The following is a description of a gene set: Human Gene Set: GOBP_PROTEIN_N_LINKED_GLYCOSYLATION_VIA_ASPARAGINE studied in species Homo sapiens The glycosylation of protein via the N4 atom of peptidyl-asparagine forming N4-glycosyl-L-asparagine; the most common form is N-acetylglucosaminyl asparagine; N-acetylgalactosaminyl asparagine and N4 glucosyl asparagine also occur. This modification typically occurs in extracellular peptides with an N-X-(ST) motif. Partial modification has been observed to occur with cysteine, rather than serine or threonine, in the third position; secondary structure features are important, and proline in the second or fourth positions inhibits modification., and this is the list of marker genes: DHDDS, ALG11 (NCBI Gene Id 440138), MAGT1, ALG8, ALG2, B4GALNT2, MPDU1, NUDT14, UBE2J1, RFT1, DOLPP1, ALG10B, ALG10, ALG6, TUSC3, MGAT1, DDOST, DPAGT1, FUT8, OSTC, NUS1, UGGT2, UGGT1, MGAT2, RPN1, ALG13, ST6GAL1, OST4, ALG9, STT3A, ALG1, DPM1, ALG12, ALG5, DAD1, ALG14, MGAT5, SRD5A3, DERL3, ALG3, KRTCAP2, STT3B, DOLK